Given this list of marker genes NR4A3, TMC2, ZPLD1, TMC1, SLITRK6, here is a description of the gene set: A reflex process in which a response to an angular or linear acceleration stimulus begins with an afferent nerve impulse from a receptor in the inner ear and ends with the compensatory action of eye muscles. Signaling never reaches a level of consciousness. Human Gene Set: GOBP_VESTIBULAR_REFLEX studied in species Homo sapiens